Given this list of marker genes IL1R1, CD81, FBXO38, SECTM1, MAP3K7, TRAF6, TBX21, IL18R1, IL12RB1, PTPRC, HLA-A (NCBI Gene Id 3105), IL23R, CD1E, CD1C (CD1c molecule), CD55, FOXP3, HLA-F, B2M, IL1B, SLC22A13, PVR, KLHL22, IL18, HLA-C, RSAD2, RAET1G, RAET1E, HLA-DRB3, TRAF2, IL12A, CYRIB, HLA-E, IL4, IL6 (NCBI Gene Id 3569), CD1D, IL12B, IL23A, NECTIN2, SASH3, CD1A, P2RX7, CD1B, MR1, SLAMF1, TNFSF4, MALT1 (NCBI Gene Id 10892), NLRP3, PRKCZ, HSPD1, CD7, DENND1B, TAP2, ZBTB1, XCL1, ARID5A, PRKAA1, FZD5 (NCBI Gene Id 81561), AZGP1, ULBP2 (NCBI Gene Id 89934), GATA3 (GATA binding protein 3), RAET1L, STX7, HLA-DRB1, HLA-G, HLA-B, ULBP1, ZP3, FADD, HLA-H, HLA-DRA, YWHAG, ULBP3, here is a description of the gene set: studied in species Homo sapiens Human Gene Set: GOBP_POSITIVE_REGULATION_OF_T_CELL_MEDIATED_IMMUNITY Any process that activates or increases the frequency, rate, or extent of T cell mediated immunity.